The following is a description of a gene set: Human Gene Set: PULVER_FOREY_PERTURB_ATTRITION_G1_S Transcription regulation during the cell cycle is crucial for ensuring genes are expressed at the right time and in the correct amounts, coordinating key processes like DNA replication, mitosis, and cell division. In our study, species: Homo sapiens Genes whose depletion leads to accumulation of cells in G1/S (pVal < 0.05) in K562 Repogle et al., 2022 reanalyzed with Velocycle from Lederer et al., 2024, and this is the list of marker genes: RAB14, CYB5B, IGFBP4 (NCBI Gene Id 3487), PARVB, SPATS2, ILRUN, MCM3, GLYR1, AP1G2, CAMSAP1, H4C11, PFDN1, NUP35, MED10 (NCBI Gene Id 84246), HOXD8, TMEM209, WDR54, TEX10, CCDC18, RPL19, MED30, ARFGEF1, ASH1L, SIRT6, TOB1, POLR3B, TOM1, FANCB, ZNF629, DBN1, CD53, RNF40, SMARCD1, NMU, PIK3C3, COX15, CRYZL1, ZNF586, SWI5, GPN3, ALDOA, PIP5K1A, TMEM245, WIPF2, C8orf82, NCBP2, SELENOK, RBM7, ICAM2, MLLT6, RPL18, SORT1, ACTR2, KLF8, OTP (NCBI Gene Id 23440), BCS1L, MED6 (NCBI Gene Id 10001), ZNF233, GTF3C2, RPL26 (ribosomal protein L26), MPV17L2 (MPV17 mitochondrial inner membrane protein like 2), PAX2, MAP3K8, XRCC3, HBG2, VEZT, GALNT12, USP14, C6orf136, ADAM10, RPUSD1, RFC4, ALDH1B1, SPINDOC, TGIF1, GYPC, SERPING1 (NCBI Gene Id 710), ATAD3B, QKI, ZNF717, ZNF574, KCNK5, ERP44, MMP17, AKT2 (AKT serine/threonine kinase 2), STIL, RBM4, GTF2H1, NVL, LSM6, PMPCB, ST7, CCNF, DYNLL2, JTB (jumping translocation breakpoint), MZT1, CCDC125, CFAP251, DHRS2, DENR, ZNF257, FASTKD5 (NCBI Gene Id 60493), ZNF334, MOB3B, GEMIN8, MRRF, MTA1, NAP1L4, DHPS, MGRN1, FBXO21, MED13, C1orf131, HNRNPUL2, TANGO6, NFAT5, DNLZ, TCEANC2, CARM1, BUB3, MTBP, NEDD8, VMP1, CCDC6, EIF4G1, PLD1, UTP18 (NCBI Gene Id 51096), XPO1, THOC3, GTF2A2, CINP, NELFA, SF3B3, WASHC5, LYZ, EIF4A1, FKRP, NASP, APOBEC3C, AFG2A, MED7, SUPT5H, PSKH1, RNH1, TICRR, EXTL3, PSMD4, RPL24, TAF1, MAN2A2, MOB4, ZNF785, IDE, DONSON, OR2T29, SPATA22, NELFE, ATP5F1D, NEDD1, USP53, ATP2B4, ATR, SKIL, PEDS1, MED14, MED4, SLC1A5, NECTIN2, TTF2, DYRK3, PHB2, NUP37, ELOF1, BRAP, GINS2, PPP2CA, PACS1, CDC25B, VPS29, TESC, RAC3, PIAS4, POLR2B, GSC, UBP1 (upstream binding protein 1), TAF2, POLG2, PRUNE1, RBBP4, RPAP1, AHCY, PKN3, SIN3A, SLC25A21, NAA38 (N-alpha-acetyltransferase 38, NatC auxiliary subunit), RAB4B, NUP98, GINM1, RBBP5, CUL1, NUMA1, CREBBP, LCE1C, CEP78, GET3, CMTR1, COPS6, SOX15, PFDN2, CNOT2, PTER, ZKSCAN2, RINT1, FAM120C, LSG1, HARS1, U2AF1L4, GTF3C1, CHAF1B, OXNAD1, HAMP, EIF4E, MAD2L1, HGS, VAMP3, MCM5, GGPS1, INTS2, PRKAR2B, TSR2, ISY1, MED22, ELMOD3, PGP, MCM6, SUCLG2, DPAGT1, GINS4, KLHL17, CTCF, USP19, LEPROT (leptin receptor overlapping transcript), ZNF277, MSANTD4, SSRP1, MXRA7, CABIN1, ZNF461, TRAM2, ZNF835, ATRIP, RPS6, AR, USP3, AKIRIN1, CCDC86 (NCBI Gene Id 79080), TOPBP1, LIPT1, NUDCD3, SH3GL1, MCM4, ZNF714, TRPV2, PDPK1, PGGT1B, MDN1 (NCBI Gene Id 23195), ZSCAN18, ARHGAP5, UQCC4, RAD21, NUP85, DNTTIP2, RABGGTA, INTS3, OCEL1, FAM131A (family with sequence similarity 131 member A), GNL1, CPSF3, ELOB, EVL, CAMLG, R3HDM1, MAP4, FOS, UBE3A, STK35, CENPJ, WDR55, FGFR3, HSPA9, HEMGN, BGLAP, CREB3L2, SKA3, ACOT7, SUPT20H, XPO4, CARF, TMEM50B, SPARC, U2SURP, NDUFAF6, HAUS8, GINS1, ZNF549, TUT4, RBM15, LIN37, ZNHIT6, IKZF2, NSD3, NAA20, MAST1, ATP6V1H, SDHD, B2M, CDIPT, SNRPA, DCTN2, EPRS1, MCM2, INTS7, DDX6, ADNP, EEF2, ETV4, RPAIN, EXOSC8, BCORL1, DAD1, SNRNP48, RELN, ATP6AP1, ZBED1, MED19 (NCBI Gene Id 219541), HERC1, UIMC1, AATF, NAA25, CENPE, NR4A3, URB1, SLC8B1, RAB22A (NCBI Gene Id 57403), SESN1, ZNF335, PPA1, RAD51 (RAD51 recombinase), TBX1, AAR2, RBM17, INF2, HBS1L, ZNF143, YJU2, DMBX1, ULK3, TBCE, TOP3A, SMC1A, ERCC2, ZDHHC7, TVP23C, TMEM161B, PMM2, UBQLN4, CSE1L, GFER, ASB1, ZBTB25, RPLP2, SRP9, FOXN2, TPR, ADAT3, PABPC4, HELQ, ZBTB9, SKP2, NDUFB4, DBF4, MED17, CCND3, ABHD6, ORC1, PPAN (peter pan homolog), MTCH2, TOE1, MCM10, FUBP1, CNOT3, THOC7, SLX4IP, MIS18BP1, MAP2K1, MED20, SOCS4 (NCBI Gene Id 122809), TMX2, BMP1, ZNF354C, TOMM22, COIL, ARHGAP6, PIM2, DLD (NCBI Gene Id 2654), CDC16, HOXC12, ZNF217, ZBTB44, FUBP3, SRRT, ZFP91, ONECUT2, PAX1, HPS3, SLC4A2, ATP1A1, NAMPT, GNA13, SFXN1, ATOH1, JRK (NCBI Gene Id 8629), EXOSC3, NANOGNB, SAMM50, STMP1, DOLK, COG1, MRPL54, GTF3C3, HNRNPD, FAM136A, DNAJB6, POU2F1, NUDT21, ZBTB32, CPSF6, FRG2, ZGPAT, TM9SF4, ATP13A1, ZC3H13, EIF3E, SKIC8, MAD2L2, RPS10, PRSS57, BANF1, HSCB, STOM, TEKT4, RAP1GDS1, DNAJC19, NUP54, PDS5B, MPPE1, SPDL1, TPX2, HNRNPM, IPO7, TMCO6, ZFTRAF1, NIFK, RNF114, RRN3, ATP6V1G1 (ATPase H+ transporting V1 subunit G1), MIB1, PPFIA1, ASCC2, CCNC, STEAP3, METAP2, TFG, WDR1, RFC2, MAPRE3, AXIN1, RPS12, TSPAN14, METTL17, TBC1D5, GTF2H4, SUPT6H, SDC3, MMS19, LRRC37B, GPRC5C, WDR89, AKT1S1, ZNF92, VARS1, PGAM1, AGO1, DHODH, ZMAT1, THUMPD1, GTF2E1, RPL22, VCF2, ABCE1, DBF4B, TRIM24, ZNF391, THRAP3, EIF3H, ACTR10, HSP90AB1 (heat shock protein 90 alpha family class B member 1), DHX15, CCNB1IP1, TSG101, ZNF674, FARSA, DTL, ZNF222, MRPL13, HUS1, ZNF160, SLC39A9, ZNF853, SREK1IP1, PSMA3 (proteasome 20S subunit alpha 3), CENPT, EIF2B5, CBX6, TCERG1, DDX41, MED12, PRPF39, CWC25, BABAM2, UBE2I, GAB2, PIGO, ZNF865 (NCBI Gene Id 100507290), CHMP6, ZC3H7A, C9orf85, SMUG1, GNL2, SDAD1, TMEM199 (transmembrane protein 199), WDR7, TRIT1, SCNM1, SHMT2, PDGFA, EXOSC6, VDAC3, PTDSS2, ZFYVE27, FUT1, ZNF695, CCDC167, CXXC1, THEMIS2, KANSL2, SNX8, HJURP, SP7, SNRNP35, GPN1, MED11, PA2G4, FEZ2, MCEE, IGSF8, UBAC2, DMRT3 (doublesex and mab-3 related transcription factor 3), POLR2M, AKAP1, NLE1, WEE1, BAZ1A, VPS37A, BCAS2, FAM83G, TIMM17B, SNRNP70, STRAP, DENND5A